Given this list of marker genes ISG20, PRKDC, RRP9, DHX37, XRCC5, UTP25, TBL3, NHP2, TSR1, BMS1, SNU13, here is a description of the gene set: Human Gene Set: GOMF_U3_SNORNA_BINDING species: Homo sapiens Binding to a U3 small nucleolar RNA.